The following is a description of a gene set: Mouse Gene Set: GOBP_POSITIVE_REGULATION_OF_CD8_POSITIVE_ALPHA_BETA_T_CELL_ACTIVATION Any process that activates or increases the frequency, rate or extent of CD8-positive, alpha-beta T cell activation. studied in species Mus musculus, and this is the list of marker genes: Runx3, Nckap1l, Xcl1 (chemokine (C motif) ligand 1), Lilrb4a, Cd244a (CD244 molecule A), H2-T23, Cbfb, Lilrb4b, Runx1, Ptpn22